Given this list of marker genes TPM2 (tropomyosin 2), PLK3, USP39, PSME3, DGCR8, COX10, PLA2G12A, BUD23, SNRPB2, PRIM2, SVIP, RRN3 (NCBI Gene Id 92636), FGF13 (NCBI Gene Id 730528), CEBPZ, PSMA8, XRCC6, GALC, LUC7L, C19orf53, RAD17, PHETA2, JKAMP, UPF3B, INTS7, CCNA2, ZNF839, SRP54, MMACHC, CDCA5 (cell division cycle associated 5), ARPC5L, NUP43, PPP1R21, IDI1, OSBPL7, DEGS1, LAIR1, BOP1, BRWD1, TRIM3, GTF2A2, SMIM13, HLCS, EPRS1, PSMD1, COPA, DOCK1, PDXDC1, PPWD1, NOP10, ANGEL1, HNRNPR, MYCBP, ENTPD5, ZNF764, ZNHIT3, NGLY1, EIF2B1, IDH3A, TMEM208, CLNS1A, SLC48A1, SPRING1, SLC4A7, TAF9, RPLP0, AKR1C4, TMEM42, CWF19L1, GCSH, PRIM1, F2RL3 (F2R like thrombin or trypsin receptor 3), SMDT1, TOM1, WDR76, DAGLB, COPRS, UTP4, NAA10, YDJC, PPM1G, NPEPL1, FKTN, SMIM15, MRPS35, PXYLP1, ATP13A3, CLPTM1L, IMP3, MAP7D1, TAF6, TTLL4, METTL24, DEPTOR, NHP2, FASTKD2, COQ4, TMEM259, PHB1 (prohibitin 1), NDUFAB1, SUPV3L1, FBXL6, RTKN, SNRPA1, RPS6KA3, C2orf42, GALNT3, NOB1, KIF20B, TFB2M, COMMD4, SLC35A4, ARFGAP2, VMP1, TTF2, FAM199X, MMUT, PRKCH, NDUFA8, RPL37A, DCUN1D2 (defective in cullin neddylation 1 domain containing 2), IARS2, AP3S2, THOC7, MCCC2, PRPSAP2, EXOSC5, DMAC1, GNPAT, CISD1, PIGN, SIRPA, MYADM, C11orf24, PHF10, ADGRG3, AKR7A2, GLE1, LPL, IPMK (inositol polyphosphate multikinase), STT3B, ANGPTL4, SLC36A4, PHTF2, ERAL1, PREB, ABHD11, TOPBP1, OTULIN, RBMX, FANCF, MANF, TARS1, RP9, TYMS, KNTC1, WDR18, SCFD2, TWNK (twinkle mtDNA helicase), NSUN2, ZC3H8, NDUFAF2, GARS1, ZBTB22 (NCBI Gene Id 9278), NME6, ALG5, HIBCH, EIF3I (eukaryotic translation initiation factor 3 subunit I), TTC4, ALYREF, SDHA, BUB3, LCLAT1, POP5, THUMPD1, FAM91A1, PPEF2, ALDH18A1, DPY30 (dpy-30 histone methyltransferase complex regulatory subunit), RMND5B, DNAJC24, AURKA, ORC6, FRA10AC1, CDV3, METTL25, NFIC, DRG2 (NCBI Gene Id 1819), PLIN4 (NCBI Gene Id 729359), CHST11, SOCS6, MTPAP, CDR2, MEPCE, STRAP, DOHH, SVIL, CNR2, LRRC20, TEX30, MPHOSPH10, here is a description of the gene set: from publication Manel N, Hogstad B, Wang Y, Levy DE, Unutmaz D, Littman DR (PMID 20829794) Human Gene Set: GSE22589_HEALTHY_VS_HIV_AND_SIV_INFECTED_DC_UP studied in species Homo sapiens Dendritic cells (DC) serve a key function in host defense, linking innate detection of microbes to the activation of pathogen-specific adaptive immune responses. Whether there is cell-intrinsic recognition of HIV-1 by host innate pattern-recognition receptors and subsequent coupling to antiviral T cell responses is not yet known. DC are largely resistant to infection with HIV-1, but facilitate infection of co-cultured T-helper cells through a process of trans-enhancement. We show here that, when DC resistance to infection is circumvented, HIV-1 induces DC maturation, an antiviral type I interferon response and activation of T cells. This innate response is dependent on the interaction of newly-synthesized HIV-1 capsid (CA) with cellular cyclophilin A (CypA) and the subsequent activation of the transcription factor IRF3. Because the peptidyl-prolyl isomerase CypA also interacts with CA to promote HIV-1 infectivity, our results suggest that CA conformation has evolved under opposing selective pressures for infectivity versus furtiveness. Thus, a cell intrinsic sensor for HIV-1 exists in DC and mediates an antiviral immune response, but it is not typically engaged due to absence of DC infection. The virulence of HIV-1 may be related to evasion of this response, whose manipulation may be necessary to generate an effective HIV-1 vaccine. Genes up-regulated in monocyte-derived dendritic cells: control versus HIV and SIV infection.